The following is a description of a gene set: species: Homo sapiens Human Gene Set: REACTOME_FATTY_ACID_METABOLISM Fatty acid metabolism, and this is the list of marker genes: DECR2, MECR, CYP4F22, PHYH, ELOVL5, ACOXL, NUDT19, PTGES2, PTGS1, CYP4B1, ACBD6, PTGES3, ACOX2, HADHB, SLC22A5, ACSL4, ABCD1, SCD (NCBI Gene Id 6319), ACACB, CYP2C9, DBI, SLC27A2 (solute carrier family 27 member 2), EHHADH, FAAH2, ABCC1, LTA4H, CPT1B, HSD17B4, ECI1, HADH, ACADVL, CBR4, ACOT2, PCTP, PRXL2B, NDUFAB1, SLC25A17, ACADM, PTGR1, ELOVL4, AWAT1, ACSM3, MAPKAPK2, CYP8B1, CROT, HSD17B3, ACSBG2, PLA2G4A, ACOT7, SLC25A20, NUDT7, ACSF3, GPX1, CYP2J2, CPT2, ALOX5AP, SLC27A3, ACOT9, ACSL5, ACSM6, PTGES, ACBD7, ECHS1, SCD5, MMAA, GGT5, HACD2 (NCBI Gene Id 9199), PRKAB2, CRAT, ACOT13, FADS2, DECR1, PON3, RXRA, ALOX15, HTD2, FADS1, HACD3, EPHX2, DPEP2, ALDH3A2, TBXAS1, AMACR, PPARD, SLC27A1, THEM5, HPGD, CYP4F8, CYP4A22 (cytochrome P450 family 4 subfamily A member 22), ALOX12, GPX4, ACACA, HACD1, CYP1B1, CYP4A11, GGT1, ACSL3, PTGR2, ACOT4, PON2, FASN, ACADS, PCCB, TECR, CYP4F11, ELOVL7, CYP4F2, ELOVL2, PCCA, ACOX1, MLYCD, HACD4, CYP1A1, ACBD4 (acyl-CoA binding domain containing 4), FAAH, CPT1A, ACOT8, HSD17B8, TECRL, ACSL6, SCP2, ALOX15B, ALOXE3, PTGDS, PRKAA2, ACOT1, DPEP1, ACSL1, PECR, ACOX3, HPGDS, CYP2U1, THEM4, ACOT12, ACADL, MCEE, PPT2, ACAA2, MID1IP1, CYP2C19, PON1, HADHA, MORC2, MCAT, CYP1A2, ELOVL6, CYP4F3, ALOX12B, ALOX5, LTC4S, ACBD5, ECI2, CYP2C8, PTGS2, ACAD10, GPX2, PPT1, CBR1, HAO2, HSD17B12, OLAH (oleoyl-ACP hydrolase), ELOVL1, PTGIS, ACAD11, PRKAG2, ACAA1, ACSF2, HACL1, ACLY, ACSBG1, ACOT11, THRSP, MMUT, ELOVL3, AKR1C3